Given this list of marker genes METTL5, ATPSCKMT, FDXACB1, RAMAC, LARP7, ICMT, WDR4, RNMT, GSPT1, PRMT5, TRMT6, TRMT2B, NSUN7, KMT5A, LCMT2, EEF1AKMT2, METTL15P1, EMG1, EEF2KMT, TRMT9B (NCBI Gene Id 57604), METTL3, EHMT2, TRMT10C, NSUN5P2, EHMT1, METTL25B, TRDMT1, ALKBH8, NSUN5, TFB1M, FBL, TRMT1L, NTMT2, SNRPF, THUMPD3, SNRPE, PRMT2, TRMT112, METTL1, MTO1, NSUN3, AKT1, METTL2A, N6AMT1, NDUFAF7, FTSJ3, SETD7, MRM3 (mitochondrial rRNA methyltransferase 3), BCDIN3D (NCBI Gene Id 144233), TRMT13, SNRPD3, SETD3, METTL21A, BHMT, RBM15B, TRMT5, DIMT1, TRMT61B, FTSJ1, NSUN2, TRMT12, HSD17B10, WDR6, METTL21C, TYW3 (NCBI Gene Id 374981), TRMT44, PRMT8, TRMO, SNRPD2, METTL15, EEF1AKMT1 (EEF1A lysine methyltransferase 1), PCMT1, TGS1, MRM2, FAM98A, METTL8, TRMT61A, HENMT1, RAB6A, PRMT1, SNRPG, METTL16, NSUN5P1 (NSUN5 pseudogene 1), NTMT1, ANTKMT, LCMT1, TARBP1, SPOUT1, BUD23, NOP2, TFB2M, NSUN6, MEPCE, METTL14, CSKMT, RBM15, THADA, METTL22, FBLL1, VCPKMT, SNRPB, NSUN4, PRMT7, MRM1, SETD2, METTL2B, METTL6, RAMACL, ETF1, TRMT10A, TRMT10B, METTL18, TRMT1, SNRPD1, SETD6, GTPBP3, SLC25A26, SMYD2, DALRD3, EEF1AKMT3, ZCCHC4, THUMPD2, PRDM12 (NCBI Gene Id 59335), FAM98B, here is a description of the gene set: The covalent attachment of a methyl residue to one or more monomeric units in a polypeptide, polynucleotide, polysaccharide, or other biological macromolecule. Human Gene Set: GOBP_MACROMOLECULE_METHYLATION studied in species Homo sapiens